Given this list of marker genes ABRACL, CIP2A, RETREG1, CHEK1, CRADD, FLVCR2, B4GALT6, TCEAL9, ELL2, MYDGF, TOM1L1, NPNT, VDR, PTPN2, BAG2, TUFT1, TGFA (transforming growth factor alpha), NUCB2, SHROOM3, MLH1, ID2, SOCS2, LIG3, LSR, ACSL4, RCN2, ETNK1, LXN, EZR, ERBB3, ATP6V1A, ENAH, ACTN4, SERINC3, CLIC1, UNC119B, PLET1, HAVCR1, KNOP1, MIEN1, CSRP1, IGF2R, MOB1B, KCNN4, ANKH, F11R, CDK1, CALM2, WEE1, CTBP2, CYSTM1, DAP, CD82, CD9, GALNT3, SLC66A2, FBXW7, NAXE, GOLPH3, TSPAN8, LMO4, SPTAN1, PPP1CB, C11orf54, HOMER2, PITPNC1, ANK3, TIAM1, KRT8, FGD1, STK39, CTSC, PAPSS1 (NCBI Gene Id 9061), SLC29A1, IER2, EHF, CCND1, ORMDL2, DOK1, ST6GALNAC4, SLAIN1, LMAN1, SRP19, F3, DDX6, DCK, TFAP2C, FHDC1, ZC3H15, CTNND1, SOX4 (NCBI Gene Id 6659), LCN2, XIST, WWC1, STRBP, LRRFIP1, RAB18, ETV1, CRYBG1, CLDN7, ATP6V1E1, TPD52L1, SLC12A2, PDIA4, PSAPL1, CMAS, SPINT1, RNF149, TRAF4, IRX3, WSB2, PERP, SERP1, SMAGP, FXYD3, NR4A1, CLDN3, IER3, ITPR2, DSG2, ALDOC, DUSP6 (NCBI Gene Id 1848), EPCAM, WNK2, TPD52, CYB561, FRRS1, TMED3, MAPK8IP1, ERRFI1, XBP1, SKP1, INPPL1, LITAF, ST3GAL5, NDST1, ATP6AP2, EBP, PTK7, FUT8, AKAP12, FLNB, RRM2, RAB10 (RAB10, member RAS oncogene family), PPP3CA, CHMP2B, IRF6, ARHGEF5, RTKN, SS18L2 (NCBI Gene Id 51188), here is a description of the gene set: Upregulation of HER2/ErbB2/Neu occurs in 15-30% of human breast cancers and correlates with poor prognosis. Identification of ErbB2/Neu transcriptional targets should facilitate development of novel therapeutic approaches. Development of breast cancer is a multistep process; thus, to identify the transcriptomes associated with different stages of progression of tumorigenesis, we compared expression profiles of mammary tumors and preneoplastic mammary tissue from MMTV-Neu transgenic mice to expression profiles of wild-type mammary glands using Affymetrix microarrays. We identified 324 candidate genes that were unique to ErbB2/Neu-induced tumors relative to normal mammary gland tissue from wild-type controls. Expression of a subset of these genes (82) was also changed in the preneoplastic mammary glands compared to wild-type controls, indicating that they may play a pivotal role during early events of ErbB2/Neu-initiated mammary tumorigenesis. Further analysis of the microarray data revealed that expression of several known transforming growth factor (TGF)-beta target genes was altered, suggesting that the TGF-beta signaling cascade is downregulated in ErbB2/Neu-induced tumors. Western blot analysis for TGF-beta-Receptor-I/ALK5 and immunohistochemistry for TGF-beta-Receptor-I/ALK5 and phosphorylated/activated Smad2 confirmed that the Smad-dependent TGF-beta signaling cascade was inactive in these tumors. Although absent in most of the tumor, phosphorylated Smad2 was present in the periphery of tumors. Interestingly, presence of phosphorylated/activated Smad2 correlated with expression of Activin-Receptor-IB/ALK4, suggesting that although Smad-dependent TGF-beta signaling is absent in ErbB2/Neu-induced tumors, Activin signaling may be active at the leading edge of these tumors. Cumulatively, these data indicate that the TGF-beta pathway is intrinsically suppressed in ErbB2/Neu tumors via a mechanism involving loss of TGF-beta-Receptor-I/ALK5. species: Mus musculus Up-regulated genes from the genes identified by two analytical methods as changed in the mammary tumors induced by transgenic expression of ERBB2. Human Gene Set: LANDIS_ERBB2_BREAST_TUMORS_324_UP from publication Landis MD, Seachrist DD, Montañez-Wiscovich ME, Danielpour D, Keri RA (PMID 15897883)